The following is a description of a gene set: Substantial data indicate that microRNA 21 (miR-21) is significantly elevated in glioblastoma (GBM) and in many other tumors of various origins. This microRNA has been implicated in various aspects of carcinogenesis, including cellular proliferation, apoptosis, and migration. We demonstrate that miR-21 regulates multiple genes associated with glioma cell apoptosis, migration, and invasiveness, including the RECK and TIMP3 genes, which are suppressors of malignancy and inhibitors of matrix metalloproteinases (MMPs). Specific inhibition of miR-21 with antisense oligonucleotides leads to elevated levels of RECK and TIMP3 and therefore reduces MMP activities in vitro and in a human model of gliomas in nude mice. Moreover, downregulation of miR-21 in glioma cells leads to decreases of their migratory and invasion abilities. Our data suggest that miR-21 contributes to glioma malignancy by downregulation of MMP inhibitors, which leads to activation of MMPs, thus promoting invasiveness of cancer cells. Our results also indicate that inhibition of a single oncomir, like miR-21, with specific antisense molecules can provide a novel therapeutic approach for physiological modulation of multiple proteins whose expression is deregulated in cancer. Genes significantly de-regulated (p < 0.05) by MIR21 in A172 cells (glioma). Human Gene Set: GABRIELY_MIR21_TARGETS from publication Gabriely G, Wurdinger T, Kesari S, Esau CC, Burchard J, Linsley PS, Krichevsky AM (PMID 18591254) studied in species Homo sapiens, and this is the list of marker genes: DDX46, STAT3, PLPP1, KBTBD6, XKR3, SLC17A5, RTF1 (NCBI Gene Id 23168), EXOC5, MTPN, USP34, PLD1, RAI14, OSR1, HOXA9, DDAH1, GNAQ, TENT5A, SLC9A6, FAM217B, ACBD5, ADGRG2, VPS13A, NFIB, UBXN4, CEP97, ENAH, LCORL, RNF38, SEC63, PBX1, HERPUD2, TPRG1L, ZBTB44, ITSN2, GLCCI1, IPP, ASRGL1, PPP1R3B, UBR5, SFXN1, TNPO1, ATF2, SCRN1 (secernin 1), TRIM38, ACTR2, AP3M1, JPH1, SAMD5, APC, SESN1, ESYT2, MYCBP2 (MYC binding protein 2), PM20D2, RSF1, PRICKLE2, TGFBR2, WNK3, AGO4, AHSA2P, RECK, RSPRY1, ANO3, TPM1, PPARA, ARHGAP21, TLR4, WWC2, SLC26A2, SLC5A3, FERMT2, ZNF587, COL5A2, USP47, MINDY2, TBL1XR1, NEK1 (NIMA related kinase 1), PTAR1, SRPK2, GPAM, PALLD, DYNC1LI2, PURB, ARMCX3, ZNF326, SKP2, NAA30, KLHL8 (NCBI Gene Id 57563), FBXO3, PHIP, SASH1, RAB6C, ARFGEF1, TTC33 (NCBI Gene Id 23548), TIMP3 (TIMP metallopeptidase inhibitor 3), KLHL24, PHACTR2, B3GNT5 (UDP-GlcNAc:betaGal beta-1,3-N-acetylglucosaminyltransferase 5), CYP4V2, CEMIP2, CERS6, ZNF292, MPDZ, NEK7, RAPH1, RUFY3, DDX3X, SNX13, ITGB8, PTBP3, SMC5, PIK3C2A, ATP11B, RASGRP1, FBXL17, MYO9A, PBRM1, GAPVD1, VASH2, RALGPS2, APAF1, CLOCK, B3GALNT1, PRRC1, CLCN5, LDAH, ZNF367, DDHD2, DDR2, LPIN1, SPG11, FAM3C, MSH2, MEGF9, NIPBL, MEIS1, GTF2A1, OLR1, LYRM7, FANCI, EIF4EBP2, SNX30, WNT5A, PTGFR, FBXO11, RABGAP1 (RAB GTPase activating protein 1), RAB11FIP2, TACC1, TOP2A, TET1, ATRX, LATS1, VPS36, RASGRP3, KLF5, CYBRD1, SMC1A, GNE, NBEA, ZNF532, MGA, LMBR1, CCDC14, ADNP (activity dependent neuroprotector homeobox), MGAT4A, GTF2I (NCBI Gene Id 90875), RP2, SUZ12, NFAT5, PKD2, YME1L1, RAB3GAP2, FIGN, SOWAHC, PAG1, BTBD7, TRPM7, DCAF10, YOD1, ATP2B4, CLIP4, PHF20L1, ARHGEF12, APOLD1, TNRC6B, SLC31A1, PELI1, GPD2, TGFB2, ZRANB1, FNBP1, FBXL5, DMD, CCT6P1, KLHL3, EPHA4, DLG1, PDCD4, LNPK, ACAP2, HAPLN1, MYEF2, COBLL1, PARP1, KNL1, RMND5A, ANKRD28, PTGR3, PTPDC1, ZMYM2, CCNG1, SREK1, GOLGA4, PTPN3, GID4, TRIM59, ZBTB20, RFX7, KBTBD7, CNTRL, CAPRIN1 (NCBI Gene Id 4076), IREB2, LPGAT1 (NCBI Gene Id 9926), CPEB3, TRAPPC2, RRAGC, WNK1, FILIP1L, TSNAX, LONRF2, YTHDC2, CUL3, FOXN3, PAN3, ZNF286A, SERAC1, SCAF11, EEIG2, TLCD4, ST6GAL1 (ST6 beta-galactoside alpha-2,6-sialyltransferase 1), CALD1, UTRN, PIK3R1, BTBD3, ZBTB38, ZYG11B, MAP3K2, EIF2AK3 (NCBI Gene Id 9451), PARP9, TRIM33, ETNK1, TRIM2, RPS6KA3, LIFR, ALS2, KLHL15, MAP3K1, POLR3B, USP7, CDC25A, ATAD2B, SPIN1, SYNE2, REV3L, RAB22A, HECTD1, SOX2, LIN7C, CRYBG1, TAF1, EXOC8, SACM1L, ARID4A, UGGT1, BRMS1L, PALS1, OSBPL3, PURA (NCBI Gene Id 5813), DOCK10, RASEF, VPS54, PRKAB2, SRSF11, THOC2, RHOBTB3, ZNF667, UBR3, PER3, LIMCH1, BMPR2